The following is a description of a gene set: from publication Cao J, Spielmann M, Qiu X, Huang X, Ibrahim DM, Hill AJ, Zhang F, Mundlos S, Christiansen L, Steemers FJ, Trapnell C, Shendure J (PMID 30787437) Mouse Organogenesis Cell Atlas (MOCA) DE_gene_main_cluster.csv, fold.change>=1.5, qval<0.05, pval<0.05 Mouse Gene Set: DESCARTES_ORGANOGENESIS_EPITHELIAL_CELLS studied in species Mus musculus, and this is the list of marker genes: Rraga, Atp2c2, Gm12446, Perp, Lnx1, Patj, Pdlim1, Ntf5, Klf5, Cldn8, Acp3, Ikzf2, Gjb6 (gap junction protein, beta 6), 9330162012Rik, Tspear, Lama5, Scin, Mapk13, Itga3, Gjb3, Prom2, Cdh1, Vstm5, Cldn4, Sema3c, Tmem220, Vwa2, Gm35021, Ccdc68, 4933417C20Rik, Sptlc3 (NCBI Gene Id 228677), Arhgap8, Ugt2a2, Mal2, Aox2, Fhip1a, Cpz, Ap1m2, Wfdc2, Plch2, AU022754, Ap1s3, BC006965 (NCBI Gene Id 675114), Spint2, Ildr1, Fam83b, Cdh3, Esrp2, Tacstd2, Paqr5, Fam174c, 1700011L22Rik, Krt15, Mab21l3, Sycp2l, Cldn6, Cblc, Col17a1, Elf5, Mid1, Irf6, Cldn23, Lypd6b, Gabrp, Fat2, Macc1, Lad1, Mir205hg, Tmem200c, Krt14, Eps8l1, Galnt18, Pof1b, Grhl3, Sh3rf2, Rfx6, Kdf1, Nipal2 (NCBI Gene Id 77238), Bcam, Plcd3, Fras1, Gm10406, Arhgef16, Ovol2, Zfp385c (zinc finger protein 385C), Mctp2, Prlr, Platr21, Macrod2os1, Vwde, Zfp1007, Glt28d2, Lamc2, Ifnlr1, Epha1, Cldn7, Adrb1, Adam28, Lax1, Arhgef19, Mfge8, Prss41, Kcnk1, Fzd6, Sfn, Fermt1, Wnt9b, Cers3, Arhgef38, Trp63, Galnt3 (NCBI Gene Id 620893), Osbpl3, Gm16136, Rbbp8, Pkp3, Tmem30b, Gpr87, St14, Lsr, B3gnt7, Lgr6, Ttll10, Cxcl14, Epcam, Vdr, Ripk4, Tmprss2, Itgb4, Nectin4, Firre, Marveld3, Gjb2, Wnt4, Gm26550, Unc5cl, Ctdspl, Ect2l (epithelial cell transforming sequence 2 oncogene-like), Esrp1, Terb1, Cftr, 2310002F09Rik, Myo5c, Oc90, Bmp8b, Tmco6, Nr2e3, Ppl, Abca12, Krt7, Frem2 (Fras1 related extracellular matrix protein 2), Spint1, Mpp7, Gm15538, Pwwp2b, Barx2, Scnn1b, Il17re, Hunk, Pla2r1, Pkp1, Gm33050, Sema3e, Susd4, Tac2, Prss8, Crybg1, Wnt6, Jag2, Lamb3, Dgka, Llgl2, Slc66a3, Edar, 1110019D14Rik, Vtcn1, Filip1l, Tmem45b, Gm13219, Pyurf, Fyb2, Cyp2s1, Exph5, Krt5, Grhl2, B4galnt2, Cdcp1, Map3k21, Tmem54, Nepn, Arfip1, Mas1, Tbc1d2